The following is a description of a gene set: Any process that modulates the frequency, rate or extent of a process involved in the formation, arrangement of constituent parts, or disassembly of cell projections. Human Gene Set: GOBP_REGULATION_OF_CELL_PROJECTION_ORGANIZATION species: Homo sapiens, and this is the list of marker genes: CDK5, RABEP2, TBC1D13, RAP1A, TOX, KANK1, PTPRO, ALKAL1, SFRP2, DYNC2LI1, PTK6, CDKL5, FAM110C, GFAP, RGS2, FGF13, CAMK1, MEGF8, PDPN, MT3, GSK3A, LIMK1, TBX6, TBC1D1, KHDC3L, BDNF, CD44, EVI5L (ecotropic viral integration site 5 like), FBXO38, TANC2, STK25, DBN1, WNT3A, SEMA6C, SFRP1, EPO, RYK, NCK1, FRMD7, NLGN1, SRGAP2C, TRPC5 (transient receptor potential cation channel subfamily C member 5), AKIRIN1, UST, DDX56, PAK2, ACTR3, SPRY2, EFNB3, CAMSAP2, BRSK2, MIR200C, CDC20, CLRN1, TTBK2, KIF26A, NTN1 (netrin 1), FUT9, BRSK1, ARF6, TBC1D14, ANAPC2, CNTROB, FNBP1L, SETX, RTN4, PIK3CA, ARC, ITGA6, MAP2, ANKRD27, CARM1, NEDD9, LZTS3, TBC1D3, PPP1R35 (protein phosphatase 1 regulatory subunit 35), PTPRG, TCHP, ABL1, PPP2R5B, EPHB2, TENM2, CARMIL2, SEMA7A, ATP8A2, CFL1, KIT, ADAMTS16, TENM1, TGFBR1, MBOAT1, DOCK11, DEF8, DMD, SEMA4D (NCBI Gene Id 349236), SCARB2, SPOCK1, MYLIP (NCBI Gene Id 29116), FYN, ZNF804A, LRRC7, MIR210, TBC1D10A, MIR219A1, TIAM1, TRPC6, ULK2, LYN, MGARP, EPHA2, C15orf62, BMP5, RIPOR2, NDRG4, FSTL4, CAV1, AUTS2, PLCE1, NGF, EFNB2, EPHB3, MAK, NEDD4L, RIT2, NCKAP1, RTN4RL2, NTNG1, ARHGAP4, NDNF, KAT2A, DZIP1, TWF1, CUL7, LPAR3, MAP3K13, CCP110, CDC42EP4, CSMD3, ICAM1, BRK1, AMIGO3, PRAG1, CENPJ, FKBP4, NIN, GDI2 (GDP dissociation inhibitor 2), KATNB1, ABI2, MIR30B, PFN2 (profilin 2), FGFR1, CEP135, SARM1, MAP6, CNTN2, VIL1, MYO3B, WASHC1, SIPA1L1, SKOR2, RREB1, YAP1, CEP97, SRC, PPFIA2, RAB21, SERPINF1, FCGR2B, APOE, SPP1, EZR, CARMIL1, PTK2B, RAB11FIP3, YWHAH, CUX1, TBC1D8, PTK7, VEGFA, ODF2L, GRIN2B (glutamate ionotropic receptor NMDA type subunit 2B), IFRD1, TBC1D30, CLN3, FZD4, NTRK2, CXCL12, ARMCX5-GPRASP2, SEMA3G, WNT7A, WASHC5, NEFL, PLS1, PRRX1, HECW1, CTNNA2, KAT2B (NCBI Gene Id 8850), ZNF296, NRDC, ARHGAP24, ODAD3, RAB17, SHANK3, GFI1, NTNG2, STK11, NFATC4 (NCBI Gene Id 4776), DVL3, CHRNB2, GSK3B, RAB29, TBC1D7, DRAXIN, MAP1B, ARPC2, IL1RAPL1, NEU4, ZMYND10, TENM3, MIR214, SEPTIN7, KIAA0319, SEZ6, TAPT1, IL15RA, ABITRAM, SYNE2, TBC1D17, SLC39A12, RCC2 (regulator of chromosome condensation 2), ITGA2, CDH4, CDC42EP3, RP1, TBC1D9B, MYO3A, PQBP1, PLXNA3, ODF2, P2RY12, ARHGAP33, DGKG, RTN4IP1, SKIL, SHOC2, BMP7, TSKU, CAMK2B, SHOX2, VPS35, TBC1D10B, ERMN, MSTN, PAQR3, EPS8L3 (EPS8 signaling adaptor L3), HECW2, TBR1, NEURL1, HSP90AA1, ANKRD1 (NCBI Gene Id 27063), EHD1, MOV10, PRNP, ROBO2, CORO1B, TUBB2B, DENND5A, INS, LRRK2, HTT, TRAK2, MARCHF7, WASL, LRIG2, RTN4RL1, NOTO, MTOR, TRIM32, ARHGAP44, SF3A2, NPTN, VLDLR, BAG5, LIMK2, TRPV2, SHTN1, DTNBP1, CYFIP1, GRN, EFNA1, TIAM2, SH3YL1, ACAP3, PIK3R1, TRIM46, MARK4, RNF6, EVL, ZNF365, PLEKHM1, DVL1, TACSTD2, DMTN, FAT3 (FAT atypical cadherin 3), SPRY3, PLXNB2, RTN4R, SEMA3A, SEMA3F, CD38, RAC2, CRABP2, FN1, PROM2, NR2F1, STYXL1, GRIP1, PLEK2, PSEN1, DAAM2, MAP4, TBC1D24, ITM2C, GRID2, FIG4, TRPM2, ACP4, SEMA4F, ROBO1, ALKAL2, EZH2, GOLGA4, RELN, POU4F2, CCL19, PLA2G3, TGFB3 (NCBI Gene Id 7043), PLPPR5, PREX1, SNAP25, GPC2, RTCA, MIR196A1, NRP1, PAFAH1B1 (platelet activating factor acetylhydrolase 1b regulatory subunit 1), NR2E1, FER, RAP2A, EPS8, NEDD4, MIR222, IFT88, DHX36, TBC1D22A, FEZF2, SNX3, ZFYVE27, AP2A1, L1CAM (NCBI Gene Id 4268), CDKL3, PTEN, LRRC4C, NGEF, CDC42EP2, DPYSL3, SEMA6D, APC, ADNP, DPYSL5, F2RL1, CDK5R1, ZEB2, DCDC2, ANLN, CFLAR, SERPINI1, ARAP1, NTRK1, DLG4, NRXN1, RAB5A, HRAS, RAB3IP, P2RX7, EVI5, ATF1, KLK6, PMP22 (peripheral myelin protein 22), SAXO1, ADAM17, DVL2, KIDINS220, PALM, PLXNB1, GAP43, ATOH7, SS18L1, MCIDAS, FBXW8, TMEM106B, CCR7, WNT1, ARF4, STX1B, CHN1, PARP6, ENPP2, KREMEN1, INTU, NEO1, EPHA3, TNN, DYNLT2B, BMPR2, CIMAP3, DAB2, SRF, CAPRIN1, RETREG3, NCS1 (NCBI Gene Id 23413), THOC2, FBXO7, TLX2, MYCBP2, NRCAM, APBB1, ADCY10, CDC42EP1, MDM2, FMR1, PRKCI, B2M, ZDHHC15, MNS1, ATP8B1, MAP2K2, MIR431, DDR2, HES1, SMAD1, SPART, EFNA5, EP300, ATG5, TRIM67, CDHR2, RDX, NEGR1, LTK, EPHA4, ISLR2 (NCBI Gene Id 57611), INPP5J, CERS2, WDPCP, ACTR2, RABGAP1, PTPRS, PLXND1, PLD1, LPAR1, WASF2, ABI3, SDCCAG8, STAU2, TNFRSF12A, ATG3, FSCN1, BIN3, MACF1, LZTS1, MARK1, KLF4, GPRASP3, SMURF1, ARPIN, AKT1, KEL, INPP5F (inositol polyphosphate-5-phosphatase F), TBC1D2B, RHOG, GDI1, CAPRIN2, GATA3, KIF24, DKK1 (dickkopf WNT signaling pathway inhibitor 1), P3H1, POU3F2, WDR44, USP6NL, EPHA7, WNT3, NCKIPSD, ITGA3, ITPKA, KLF5, CHODL, TBC1D22B, NTRK3, CDKL1, NDEL1, CBFA2T2, STAP1, TNIK, MAGI2, PDLIM5, SDC2 (NCBI Gene Id 6383), EPS8L1, PTPN1, VIM, WRAP73, DGUOK, CCL21, CYLD, COBL, SEPTIN9, TMEM30A, CDHR5, BMPR1A, RALA (NCBI Gene Id 5898), HAP1, KIF21A, LUZP1, S100A9, CNTF, RUFY3, RHOA, EFHC2, TNR, YTHDF1, NSMF, GPM6A, AGRN, ATMIN, TESK1, FZD1, CTTN, MARK2, SGSM3, PLK5, MAG, BAIAP2, PRKCD, PACSIN1, CORO1C, TRAK1, P2RX4, TBC1D19, ATP1B2, USP17L2, CAMK2G, TBC1D2, USH1C, FAM98A, SLIT1, IFT20, ULK4, CRKL, IST1, BBS4 (Bardet-Biedl syndrome 4), CHRNA3, IFT140 (NCBI Gene Id 9742), PRKD1, TBC1D21, EPS8L2, FES, TBC1D5 (NCBI Gene Id 9779), MYO10, FIGNL2, BRAF, ARHGEF7, PTPN9 (protein tyrosine phosphatase non-receptor type 9), KDM1A, ROBO3 (NCBI Gene Id 64221), HOMER1, GLCE, PTPRF, SLITRK1, ARSB, CIB1, CRK, CEP120, HDAC6, TWF2, WAS, MIEN1, ARHGAP35, ADGRB3, CDC42, EEF2K, BCL11A, CDK10, OCLN, TREM2, MDK, STK24, NEUROG3, DAB2IP, DCC, TBC1D20, WNT5A, GAK, FUZ, CROCC, PAK1, MIR221, RAPGEF1, MIR133B (microRNA 133b), NOVA2, PAK3, THY1 (Thy-1 cell surface antigen), MPHOSPH9, RHOQ, DAB1, ADCY6, SLC30A1, CX3CL1, FEZ1, GORASP1, MFSD2A, HRG, CCDC88A, DSCAM, MYO9A, PLXNB3, RGMA, RND2, SYNGAP1, ALK, RAPGEF2, SCN1B, SEMA5A (semaphorin 5A), TBC1D10C, RAC1, LRP8, MCF2, ZMYND8, DISC1, SLIT2, PPP1R16B, HDAC2, CRMP1, KIF1A, DIP2B, MAPK15, LCN2, ENC1, ABL2, CDH1, XK, CAMK1D, DDR1, MINAR1, PTN, TRPV4, METRN, SNAPIN, CUX2, RAP1GAP, MIR21, PTPRD (protein tyrosine phosphatase receptor type D), TBC1D15, OBSL1, PLXNC1, CNTN1, MAPT, AMIGO1, PODXL, AVIL (NCBI Gene Id 80056), PFN1, LIMA1 (NCBI Gene Id 51474), APP, ULK1, RET (ret proto-oncogene), SCARF1, KNDC1, NFE2L2, STMN3, NUMBL, PUM2, CDC42EP5, STMN2, ABHD17B, LRP4, SRCIN1 (SRC kinase signaling inhibitor 1), RAB11A, RAB8B, MAP2K1, KIF13B, PPP3CA, KCTD17, ENTR1, TBC1D16